The following is a description of a gene set: studied in species Homo sapiens Reactome Pathway: Long-term potentiation part of: Post NMDA receptor activation events In long-term potentiation (LTP), involved in learning and memory, a brief period of synaptic activity induces a lasting increase in the strength of the synapse. LTP is initiated by NMDA receptor-mediated activation of calcium/calmodulin-dependent protein kinase II (CaMKII), followed by binding of CaMKII to the NMDA receptor and CaMKII-mediated phosphorylation of AMPA receptor subunits., and this is the list of marker genes: GRIA2, NRG1, DLG4, CALM1, CAMK2D, GRIA1, CAMK2B, GRIN2B, GRIN2D, SRC, GRIN2C, LRRC7, DLG1, ACTN2, DLG2, ERBB4, GRIN2A, NEFL, CAMK2A, NRGN, CAMK2G, GRIN1, DLG3